The following is a description of a gene set: Human Gene Set: MIR3189_3P Genes predicted to be targets of miRBase v22 microRNA hsa-miR-3189-3p in miRDB v6.0 with MirTarget v4 prediction scores > 80 (high confidence targets). from publication Chen Y, Wang X (PMID 31504780) species: Homo sapiens, and this is the list of marker genes: NEUROD2 (neuronal differentiation 2), UBE3A, RBMXL2, FNIP1, DLL1, SPAG8, SH3PXD2A, VEZF1, HINFP, MAB21L2, JADE2, ZBTB26, TLE4, OSCAR, SF3B2, ADGRF5, ALS2, FGA, ENSA, CALN1, ZCCHC24, SERPIND1, SRGAP2, PSMF1, ARHGEF25, KAT7, CHTF8, ZNF646, PIGL, BBS7, CORO2B, RERE, ZBED4, CTDSP2, ZNF736, EFNA4, PLD1, PAAF1, NECTIN2, PDIA3 (NCBI Gene Id 2923), MOB2, GGCX, BACH2, CHST11, TAF4B, NPY1R, RASSF3, HMGCLL1, TAFA1, BLCAP, IFFO2 (intermediate filament family orphan 2), ZNF518A, ETF1, CDC25A, SPEN (spen family transcriptional repressor), PCNT, MICU3, GPR158, FAM234A, MGA, RBMX (RNA binding motif protein X-linked), MEX3C, MAP1A, DNAJC11 (NCBI Gene Id 55735), ST6GAL1, BTBD9, STEAP1B, ACVR2B, UVRAG, IKZF4, KCNQ3, PHF20L1, SAXO1, EFTUD2